Given this list of marker genes PFDN6 (NCBI Gene Id 10471), PFDN5, VBP1, PFDN4, PFDN2 (prefoldin subunit 2), PFDN1 (NCBI Gene Id 5201), here is a description of the gene set: studied in species Homo sapiens Human Gene Set: WP_CELLULAR_PROTEOSTASIS Cellular proteostasis